Given this list of marker genes Orc1, Orc2, Orc3, Orc4, Orc6, Kpna1, Kpna6, Orc5, Kpnb1, here is a description of the gene set: Assembly of the ORC complex at the origin of replication Mouse Gene Set: REACTOME_ASSEMBLY_OF_THE_ORC_COMPLEX_AT_THE_ORIGIN_OF_REPLICATION species: Mus musculus